The following is a description of a gene set: Human Gene Set: HP_OSTEOLYSIS_INVOLVING_BONES_OF_THE_UPPER_LIMBS species: Homo sapiens Osteolysis involving bones of the upper limbs, and this is the list of marker genes: RETREG1, HPGD, ATL3, MMP2, BANF1, DDR2, LMNA, MTX2, PDGFRB, RIGI, MMP14, NOTCH2, MAFB, COL3A1 (collagen type III alpha 1 chain), WNK1, ZMPSTE24, CTSC, CTSK, SCN9A, KIF1A, IFIH1, FLNA, ASAH1